Given this list of marker genes Abl1, Ccr7, Ptpn22, Scrib, Ticam2, Gimap5, Nfkbiz, Hspd1, Kctd9 (potassium channel tetramerisation domain containing 9), Fadd, Hmgb1, Zfp683, Irf8, Lta, Ifnar1, Gata3, Cd2, App, Pde4b, Cd27, Avpr2, Zp3, Gas6, Txk, Wnt5a (wingless-type MMTV integration site family, member 5A), Trim27, Pycard, Gimap3, Prnp, Hras (Harvey rat sarcoma virus oncogene), Crtam, Uba5, Il36rn, Eomes, Cyrib, Itk, Azi2, Nr1h4, Enpp1, Il23a, Cd226, Cd96, Ripk3, Il33, F2rl1, Lilrb4a, Il21, Runx1, Tlr3, Ifnb1 (NCBI Gene Id 15977), Laptm5, Sash3, Bcl3, Ddit3, Klrk1, Havcr2, Tlr8, Raet1d, Cebpg, Vsir, Cd244a, Il2, Slc7a5, Slc11a1, Arid5a, Vtcn1, Nras, H2-M3, Rara, Runx3, Scgb1a1, Mir21a, Carmil2 (capping protein regulator and myosin 1 linker 2), Pglyrp4, Il12a, Tlr9, Abl2, Il20rb, Pglyrp3, Il12b, Il23r, Cd40lg, Cd160, Isl1, Tnfsf9, C1qbp, Tnfsf18, Lilrb4b, Foxp3, Cd276, Clec7a, Il18rap, Ulbp1, Axl, Il1b, H2-Q7, Cd47 (NCBI Gene Id 78539), Ripk2, Tnf, Il27ra, Il18r1, Tlr4, Lgals9, Il12rb2, Pde4d, Jak2, Klre1, Cd3e, Il27, Cd274, Fzd5, Tyk2, Il1r1, Tcirg1, Sh2d1b1, Gadd45g, Nlrp6, Il1rl1, Il12rb1, Ccr2, Il10, Irgm1, Ufsp2, Nod2, Flt3, Rasgrp1, Il18, Sirpa (signal-regulatory protein alpha), Zc3h12a, Slamf6, Zfpm1, Tnfrsf13c, Isg15, Zg16, Abcc1, Tlr7, Pglyrp2, Cd1d1, Tnfsf4, Gpr141, Rnf19b, Cd14, Xcl1, Ufc1, Mir155, Pdcd1lg2, Slamf1 (signaling lymphocytic activation molecule family member 1), Pglyrp1, here is a description of the gene set: The appearance of interferon-gamma due to biosynthesis or secretion following a cellular stimulus, resulting in an increase in its intracellular or extracellular levels. Interferon-gamma is also known as type II interferon. studied in species Mus musculus Mouse Gene Set: GOBP_TYPE_II_INTERFERON_PRODUCTION